Given this list of marker genes KIF18A, THTPA, FANCF, PSME1, PMF1, RPA2, NCOA7 (nuclear receptor coactivator 7), HEBP2, POLD1, CCDC14, ARSB, MRPL47, VSIG10, BUB1B, TNFSF10, BEX4, SSBP3, STK39 (NCBI Gene Id 27347), EME1, RAD54L, ATP2B1, PDHB, PSMB4, SFTPA1, CALCRL, PTPA, MRPL50, SLF2, NOL7, CBX5, ILK (integrin linked kinase), MRPL2, PTX4, NFE2, WDR90, OR10AD1, ABHD1, ZDHHC15, AFMID, SPECC1L, CHTOP, CKAP2, ELL3, LPAR3, GALNTL5, CDKN1C, TTC23L (NCBI Gene Id 153657), FANCG, RHBDD3, PLXND1, FIGNL1, ERH, CKS1B, TROAP, SPAG5, MRPL39 (mitochondrial ribosomal protein L39), SIK1, LSM2 (NCBI Gene Id 57819), E2F8, GBP7, CMTM7, FOXM1, CCDC77, TMCC1, COG3, MCU, PDZK1IP1, SKA2, CDCA8, SMC2, SF3A3, RFC1, TPGS2, PRKAG2, COTL1, DIAPH3, FXN, RIN3, CARMIL2, CENPM, CCDC51, GINS4, FILIP1L, XIAP, TICRR, GEN1, TANK (NCBI Gene Id 10010), SERPINE2, KIF20B, TGM6, TRIAP1, TUBGCP2, IFIH1, C2CD5, C21orf91, ABRACL, MRNIP, CSK, ZNF157, CD48, MSH2, C2orf69, LRP11, MBTPS1, TMEM18 (NCBI Gene Id 129787), E2F7, THOC7, PPIH, DCP2, AKAIN1, PIP4K2A (phosphatidylinositol-5-phosphate 4-kinase type 2 alpha), CDCA5, LITAF, DZIP3 (DAZ interacting zinc finger protein 3), FBLN1, PALB2 (partner and localizer of BRCA2), MCM7 (minichromosome maintenance complex component 7), SRSF9, RFC5, VRK1, POLE, MUTYH, PASK, TIPIN, TRMT44, SLC5A3, PIGR, TRIM34, SLAMF6, TTK, ATAD5 (NCBI Gene Id 79915), ARHGAP23, KLK11, DCK, VMA21, SUCO, BLVRA, PDE7A, PPIC, KIAA0040, CCL4, MEAF6, TRAF5, EMC2, PLK1, RNF26, CD1D, FAF1, HEXIM2, POLE2, PRDM8, UTP11, EPDR1, CBR4, ITPR1, ASPSCR1, ORC6, XRCC2, PPA2, OSTC, TMEM109, PSMD9, ITM2A, EML3, TDP1, LRRC40, TBC1D31, CDKN2AIPNL, ZFYVE19, ANKRD27, CENPJ, PPP1R26, CCDC61, PRKCA, IRAG2, FIRRM, ZNF619, PRIM1, SERPINB9, CD96, DHDDS, MCOLN3, SOWAHC, KCNT2, CCDC28B, APIP, RACGAP1 (NCBI Gene Id 94651), SIX5, EPHB6, CERKL, PIP5K1B, CD9, RFC4, GLIPR1, SLC25A51, NSUN4, MTR, KLF4, CCDC62 (coiled-coil domain containing 62), here is a description of the gene set: Genes down-regulated in IL10 knockout macrophages: unstimulated versus stimulated by IL10 and LPS. Human Gene Set: GSE19941_UNSTIM_VS_LPS_AND_IL10_STIM_IL10_KO_MACROPHAGE_DN studied in species Homo sapiens Bone marrow-derived macrophages were produced from mice lacking IL-10 alone (IL10-def) or mice lacking both IL-10 and the p50/p105 subunit of NF-kB (p50/IL10), and left unstimulated, stimulated with LPS (1 ng/ml) or stimulated with LPS and IL-10 (0.3 ng/ml). from publication Yang HT, Wang Y, Zhao X, Demissie E, Papoutsopoulou S, Mambole A, O'Garra A, Tomczak MF, Erdman SE, Fox JG, Ley SC, Horwitz BH (PMID 21217011)